The following is a description of a gene set: species: Homo sapiens Genes up-regulated in glomeruli of kidneys from patients with diabetic nephropathy (type 2 diabetes mellitus). from publication Baelde HJ, Eikmans M, Doran PP, Lappin DW, de Heer E, Bruijn JA (PMID 15042541) Human Gene Set: BAELDE_DIABETIC_NEPHROPATHY_UP BACKGROUND: Diabetic nephropathy (DN) is a frequent complication in patients with diabetes mellitus. To find improved intervention strategies in this disease, it is necessary to investigate the molecular mechanisms involved. To obtain more insight into processes that lead to DN, messenger RNA expression profiles of diabetic glomeruli and glomeruli from healthy individuals were compared. METHODS: Two morphologically normal kidneys and 2 kidneys from patients with DN were used for the study. Glomerular RNA was hybridized in duplicate on Human Genome U95Av2 Arrays (Affymetrix, Santa Clara, CA). Several transcripts were tested further in independent patient groups and at the protein level by immunohistochemistry. RESULTS: Ninety-six genes were upregulated in diabetic glomeruli, whereas genes were downregulated. The list of overexpressed genes in DN includes aquaporin 1, calpain 3, hyaluronoglucosidase, and platelet/endothelial cell adhesion molecule. The list of downregulated genes includes bone morphogenetic protein 2, vascular endothelial growth factor (VEGF), fibroblast growth factor 1, insulin-like growth factor binding protein 2, and nephrin. A decrease in VEGF and nephrin could be validated at the protein level and also at the RNA level in renal biopsy specimens from 5 additional patients with diabetes. CONCLUSION: Results of oligonucleotide microarray analyses on control and diabetic glomeruli are presented and discussed in their relation to vascular damage, mesangial matrix expansion, proliferation, and proteinuria. Our findings suggest that progression of DN might result from diminished tissue repair capability., and this is the list of marker genes: PDE2A, ADAMTSL2, GPLD1, ACY1, ATP10B, CRHBP, BBOX1, C4A, UGT2B7, ENG, HPN, CLU, NOTCH4, ASS1, LYZ, ALDH4A1, ID1, LTK, PTPRM, FXYD2 (NCBI Gene Id 486), AKR1A1, PPM1F, HBB, PTGIS, DPEP1, MT2A, INPP5K, BAX, UNC5B, SLC6A7, STARD8, SPG7, ITFG2, UGT1A10, JADE3, ACVRL1, ACSM2A, FTL (NCBI Gene Id 93315), CTSH, GGT1, ZCCHC24, AOC1, CCL3, SLCO2A1, MT3, SLC22A6, CCND1, GAS6, CRIP1, MAP4, AANAT, VAT1, MIA2, ITM2A, IMPA2, TLE2, PLPP3, PTPRB, CAPN3, CLEC3B, TEK, FAM53B, MYC, ADGRF5, CD24, GDPD5, HYAL2, RBPMS, ARHGEF15, FBP1, TIE1 (NCBI Gene Id 7075), ICAM2, RAMP2, AQP1, CCDC69 (coiled-coil domain containing 69), PECAM1, AKR1C3, BPHL, ENO1, MT1G, ADGRG1, IGFBP5, EML1, SEMA6A, CYP4F2, HLA-DRB1, HYAL1, GAS2L1, CD34